The following is a description of a gene set: part of: MITF-M-dependent gene expression species: Homo sapiens Reactome Pathway: Regulation of MITF-M-dependent genes involved in apoptosis MITF contributes to cellular survival through regulation of anti-apoptotic factors such as BCL2 and BIRC7. Consistent with this, MITF is required for survival of melanoblasts during embryogenesis. MITF may also contribute to survival through regulation of DICER, which in turn regulates expression of a number of genes by virtue of its processing of microRNAs., and this is the list of marker genes: MOV10, BCL2A1, AGO2, HDAC1, AGO4, BCL2, MIR211, TNRC6A, TNRC6B, TNRC6C, SIN3A, TRPM1, BIRC7, AGO1, POU3F2, DICER1, MITF, HINT1, AGO3